Given this list of marker genes Stc2, Cyp2c37, Cyp2j11, Jak2, Thap4, Ptgs2, Cyp8b1, Fa2h, Hba-x, Cyp1a2, Cat, Rsad1, Cyp4v3, Cyp2b9, Cyb5a, Cyp2d26, Cyp1b1, Cyct, Cyp4a12b, Eif2ak1, Sdhc (NCBI Gene Id 98540), Cyp2c50, Fech (NCBI Gene Id 14151), Cyp2d10, Hbq1b, Cyp2c29, Cyp4f18, Cyp2c68, Cycs, Hrg, Gucy1b1, Cyp2a22, Cyp4f15, Cyp4x1, Kcnh7, Ptgis, Cyp4f14, Cyp2j5, Cyp2c69, Upk3bl, Cyp3a16, Cyp26b1, Flvcr2, Adgb, Mmachc, Lmbrd1, Cyp11a1, Hpx, Cyp3a11, Cyp4b1, Cyp51, Gucy1a1, Cyp2c23, Cyp27a1, Cyp2j7, Cyp21a1, Hbb-bt, Cyb5r4 (NCBI Gene Id 97535), Tbxas1, Hbb-bh2, Cyb5b, Hmox2, Mpo, Cyb5d2, Lpo, Cyp46a1, Nos1, Ido1, Cyp2s1, Hbb-bs, Cyp2c39, Cyp2d9, Cyp2b10, Cyp7a1, Cyp2d12, Steap3 (STEAP family member 3), Cyp2c66 (NCBI Gene Id 69888), Tpo, Cyp24a1 (NCBI Gene Id 13081), Cyp2a12, Ptgs1, Tdo2, Cyp2d11, Cyp2j6, Epx, Tcn2 (transcobalamin 2), Cyp2a4, Cyp20a1 (cytochrome P450, family 20, subfamily a, polypeptide 1), Pgrmc2, Cyp2f2, Cyp2b19, Cyp2c55, Pxdn, Cbs, Slc48a1, Cyp1a1, Cyp4a10, Cyp26a1, Hbb-bh1, Cyp11b1, Cyp17a1, Cyp2e1, Nos2, mt-Co1, Hba-a1, Cyp7b1, Ngb, Flvcr1, Cyp2c38, Cyp2c70, Cyp39a1, Cyp2d22, Cyp2c67, Ambp, Cyp2j9, Cyp2u1 (cytochrome P450, family 2, subfamily u, polypeptide 1), Cyp2c40, Steap1, Cyp4a14, Cyp2ab1, Nox3, Abcb6, Cyp2r1, Cyp2w1, Mtr, Steap4, Suox, Hbq1a, Hmox1 (NCBI Gene Id 27970), Cyp4a12a, Cyp2j13, Cyp2b13, Cyba, Nox4, Mmut, Cyp2c54, Cybb, Cyp2g1, Nos3, Hbb-bh0, Cd320, Ido2, Cyp27b1, Cyp11b2, Cyp2c65, Pgrmc1, Cyp3a13, Cyp2j12, Cygb, Cyp2a5, Mmab, Hbb-y, Mb, Cyp2d34, Cyp26c1, Dgcr8, Sdhd, Src, Cblif, Cubn, Cyp2t4, Cyp2b23, Cyc1, Cyb561d2, Cyp3a25, Hebp1, Hccs, Prdx1 (NCBI Gene Id 18477), Nr1d1, Cyp2d40, Ptges2, Cyp2j8, Cyp19a1, Hebp2, here is a description of the gene set: Mouse Gene Set: GOMF_TETRAPYRROLE_BINDING Binding to a tetrapyrrole, a compound containing four pyrrole nuclei variously substituted and linked to each other through carbons at the alpha position. species: Mus musculus